Given this list of marker genes SH3PXD2A (SH3 and PX domains 2A), SQOR, CPEB2, PGAP6, FBXO4, RLF, TET1, MYO10, ARL4C, NFIX, THRA, MVD, DUSP11, RASSF2, DAP, DLG1, SLC30A7, NFIA, GARRE1, ARHGEF10, GATA3, ZFP36, HLA-DMB, ZZEF1, SPPL3, ZYG11B, USF2, TCF4, ITPRIP, FHIP2A, STAC3, KBTBD11, UBXN11, LIMD1, ACCS, FAM98C, KIF1B, ATP11B, MLLT3, HLA-DOB, LHFPL3, C19orf38, LARGE1, DAPL1, ESR1, IFITM5, FAM3A, SMIM5, SLC12A7, WLS, INSIG1, TIAL1, AP2A2, KMT2E, AMOT, TMEM94, IGFBP4, TANC1, SFSWAP, HECTD4, CDON, ALS2CL, DOCK4, ZBTB7B, TAOK3, ZMYM5, ATP13A2, UBXN6, HS3ST3B1, PRRC2B, KRTAP4-12, ZNF503, SUN1, ATP10D, CYP19A1, ZNF668, HAL, CCSER2, E4F1, FAM117B, MPND (MPN domain containing), ST6GAL1, LAT, AAMDC, LDLR, MPZL3, VAMP2, ZC3H11A, FOXN3, VAV3, LEFTY2, FRAT2, USH1C, ADGRE5, PTGS2, HMGXB3, AADAT, MFGE8, CDKN2D, RASA3 (NCBI Gene Id 22821), C5orf34, SPRY1, ZNF217, MCMBP, IFITM2, APC, PACS2, GCM2, PITPNC1, CCDC88C, ADGRB2, PODXL, FRMD6, LEMD2, NIM1K, TAFA2, ALDH5A1, PARD6G, RGMB, TBC1D17, MSS51, GSAP, SMAD7, CLCN4, CD40, SMAD4, UBN2, STAMBPL1, RBM33, LEF1, S1PR1, MGST2, IKBKB, CLN6, LAPTM4A, AMPD3, RASSF3, ACVR1B, SHE, IL17RA, THBS1, ANO10, KCMF1, TRAT1, ANXA5, AR, TMC8, PDLIM4, CCNL2, ENDOV, PPP1R15A, MID1, PCNX1 (pecanex 1), BTLA, FMO5, KLF7, C5orf63, NCBP3, SYTL2, ARHGEF3, CD6, SYCP2L, MFSD2B, TRIM56, KIAA0040, PCED1B, CFTR, FASTK, POLM, ITSN1, GGACT, PARM1, C1QB, TSPOAP1, SLC30A10, FKBP15, SYK, FOXJ2 (forkhead box J2), SEMA4A, TREX1, PTGIR, PCYT2, ZBTB20, TEF, ZIC4, IKBKE, UGGT2, FLNA, RTF1, TRIB2, ADAD1, FOS, SMOX, TREML2, ASS1, TTC21B, ST3GAL1, THRAP3, MAPK11 (mitogen-activated protein kinase 11), KCTD10, here is a description of the gene set: species: Homo sapiens The transcription factor Foxp3 is usually considered the master regulator for the CD4+CD25+ from publication Hill JA, Feuerer M, Tash K, Haxhinasto S, Perez J, Melamed R, Mathis D, Benoist C (PMID 18024188) Genes up-regulated in comparison of ActCD4TGF versus WTActCD4TGF (see Fig. 1 in the paper for details). Human Gene Set: GSE7460_WT_VS_FOXP3_HET_ACT_WITH_TGFB_TCONV_UP